Given this list of marker genes ZNHIT1, PDCD10, RBM15, RRAGC, SYNGR1, RENBP, HDAC5, PLGRKT, DPCD, CORT, LLGL1, PLEKHF2, PRKX, PIK3R1 (NCBI Gene Id 5295), ZFYVE27, NKX2-4, MLLT10, IL33, TRAF2, ETV6, IDS, RYR1, IFT22, NSG2, FOXA3 (NCBI Gene Id 3171), ZNF276, CTTN, GRM1, MANSC1 (NCBI Gene Id 54682), ALDH18A1, TFG, ZYX, HMGB2, CPTP, TLE2, TAS2R4, LAPTM4A, ALS2CL, ZNF740, HDAC7, BRMS1, INPPL1, GPCPD1, GPS2, MORC3, SPI1, RTN4, ILRUN, TBC1D15, AEBP2, TMUB2, ASB11, CMTM6, VPS35L, TCTA, TTC1, ENTPD1, RASSF8, MAT1A, SRC, RRAS2, SHARPIN, UNC50, HPS4, MARVELD2, NAA20, SOCS2, PHLDA2, EIPR1, MTA1, PRP4K, ENC1, N4BP3, PDE4A, CPT1A, PRRC2A, SH2B3, IL10RA (interleukin 10 receptor subunit alpha), CLN8, IFFO2, EFR3A (EFR3 homolog A), IL12RB2, MOCOS, LEP, INPP5K, GCNT2, PTK6, RNF130, ATL3, CD274, TSPAN2, LASP1, CUTC, KAT2B (NCBI Gene Id 8850), ST8SIA1, PUM2, FBN1, INHBA, CWF19L1, IL21R, TGM2, BRDT, SMC5, TANGO2, UBOX5, STARD3NL, CCNA1, CRIP1, TMEM184B, CASP8, MSRB1, MVP, TFIP11 (tuftelin interacting protein 11), IL12RB1, MNT, TNFAIP8L1, UBC, RCOR1, SCAMP2, TMA16, CAAP1, RIPK3, DIPK1B, SGTA, CCNG2, OCIAD1, BUB1B, TIMP2, ASGR2, TMCO3, TMEM229B, SLC25A45, CDS2, TIPARP, F10, RAB8A, MSH4, KRTAP21-1, MMP19 (matrix metallopeptidase 19), ALDH1L1, PRR15, DCAF11, MXD1, CKB, DDX3Y, NRBP1, SPPL2A (signal peptide peptidase like 2A), EPB41L2, ASH1L, NSMCE3, PRRG2, VOPP1, MLXIP, CLCN7, RBM22, EEPD1, DPYSL5, SRRD, PIAS1, TNFRSF9, AGGF1, SERPINC1, NASP, TMCC3, CST3, TXNDC17, KRT82, CA13, STAB1, RBMS2, TRDMT1, PMEPA1, FYCO1, PLEKHO2, RPAP1, ITGA4, ITPA, SLC15A4, ADNP, FSCN1, ACADL, SMPDL3A, AVL9, GREM1, RAP1B, KIAA0319L, GTF2A1, LYL1, RNF149, TAX1BP1, MAML2, PCYT1A, RASD2, PI4K2A, CCNJ, PIM1, CHTF8, CD68, RBMS1, ZNF385A, here is a description of the gene set: mouse primary BMDCs were stimulated with tlr ligands and gene expression changes were profiled on Affymetrix arrays Human Gene Set: GSE17721_POLYIC_VS_PAM3CSK4_16H_BMDC_UP from publication Amit I, Garber M, Chevrier N, Leite AP, Donner Y, Eisenhaure T, Guttman M, Grenier JK, Li W, Zuk O, Schubert LA, Birditt B, Shay T, Goren A, Zhang X, Smith Z, Deering R, McDonald RC, Cabili M, Bernstein BE, Rinn JL, Meissner A, Root DE, Hacohen N, Regev A (PMID 19729616) Genes up-regulated in comparison of dendritic cells (DC) stimulated with poly(I:C) (TLR3 agonist) at 16 h versus DC cells stimulated with Pam3Csk4 (TLR1/2 agonist) at 16 h. studied in species Homo sapiens